Given this list of marker genes UNKL, MED13, ICOS, MSI2, MARCHF6, FUBP3, IKZF5, AQP4, CACNA1G, TNFAIP1, NAA15, NHLRC3, AMBN, CNGB1, ZNF713, ARF6, GNPDA1, RSBN1L, KLHL42, QRSL1, CCDC40, SPATA1, ARL5B, VIM, UCHL5, PFKFB2, SLC44A1, MBL2, SSX2IP, CELF2, HIVEP3, TRMT2B, RBMS1, ARHGAP12, INO80D, SLC26A3, SYCP2 (synaptonemal complex protein 2), CPEB3 (NCBI Gene Id 22849), C5, GOPC, RAD51B, MGP, WDR35, STAU2, TRAF3, FAM168B, FRMD7, LRBA, CDK19, here is a description of the gene set: Genes predicted to be targets of miRBase v22 microRNA hsa-miR-28-3p in miRDB v6.0 with MirTarget v4 prediction scores > 80 (high confidence targets). studied in species Homo sapiens Human Gene Set: MIR28_3P from publication Chen Y, Wang X (PMID 31504780)